Given this list of marker genes Lyz2, Sat1, Abi3 (ABI family member 3), H2-D1, Hspa1b, Npc2 (NPC intracellular cholesterol transporter 2), Cd300a, Klf2, Pou2f2, Arl5c, Ypel3, Fau, Cybb, Cx3cr1, here is a description of the gene set: Cytokines mediate cell-cell communication in the immune system and represent important therapeutic targets. A myriad of studies have highlighted their central role in immune function, yet we lack a global view of the cellular responses of each immune cell type to each cytokine. To address this gap, the authors created the Immune Dictionary, a compendium of single-cell transcriptomic profiles of more than 17 immune cell types in response to each of 86 cytokines (>1,400 cytokine-cell type combinations) in mouse lymph nodes in vivo. A cytokine-centric view of the dictionary revealed that most cytokines induce highly cell-type-specific responses. For example, the inflammatory cytokine interleukin-1β induces distinct gene programmes in almost every cell type. A cell-type-centric view of the dictionary identified more than 66 cytokine-driven cellular polarization states across immune cell types, including previously uncharacterized states such as an interleukin-18-induced polyfunctional natural killer cell state. Mouse Gene Set: CUI_MONOCYTE_IL33_RESPONSE_DN Genes negatively differentially expressed in cell type: Monocyte upon treatment with cytokine: IL-33 in mouse lymph nodes in vivo. from publication Cui A, Huang T, Li S, Ma A, Pérez JL, Sander C, Keskin DB, Wu CJ, Fraenkel E, Hacohen N (PMID 38057668) studied in species Mus musculus